The following is a description of a gene set: Any process that activates or increases the frequency, rate or extent of vascular endothelial growth factor receptor signaling pathway activity. species: Mus musculus Mouse Gene Set: GOBP_POSITIVE_REGULATION_OF_VASCULAR_ENDOTHELIAL_GROWTH_FACTOR_RECEPTOR_SIGNALING_PATHWAY, and this is the list of marker genes: Fgf18, Tek, Hif1a, Grb10, Vegfb, Bmp4, Kdr, Mt3, Prkd2, Angpt1, Robo1, Prkcb, Fgf10, Fgf9